Given this list of marker genes NBR2, DPY30, NOL6, NSUN6, FAF1, CHEK1, TAF13, EED, ITFG1, ESYT1, KIFBP, FAM174B, MTND5P11, EMC8, CHERP, RBM33-DT, CZIB-DT, IPO8, EIF3D, PAF1, ZEB1, ZNHIT6, CEPT1, UBR1, SUPT5H, CNIH2, NBR1, GOLGA7, RAP2A, GGCX, FAM230G (family with sequence similarity 230 member G), CWF19L2, FKTN-AS1, FKBP15, MYO9A (NCBI Gene Id 80251), ASB7, KLRC2, CRLS1, EIF3K, HS2ST1, NAALADL2, MZF1, CIAO3, MBD4, ELP3, SNORD13, SELENOF, COA8, MRPS12, RPS16, FBRS, CTNNBL1, SOX2-OT, C4orf46, CEP290, PDPR, NUDT9, MT-TL1, PBRM1, NCOA5, PHAF1, SENP8, ARL5B, LSM4, GNL3, SARS2, ETFDH, RNF139, CDK8, PCNX4-DT, E4F1, LEO1, MT-TP (NCBI Gene Id 4571), FAAP100, TGDS, UTP25, ETFRF1, DNAJC9-AS1, TRAPPC5, RNF111, PHKB, DNAJC19, KLHDC9, EPRS1, PDPR2P, EIF4B, NDFIP2, C4orf36, HM13, DGCR6L, FKTN, PSMB6, EPC2, RALGAPA1, FAM229B, NDUFS5, DPH5-DT, UTP14A, TMTC3, MT-TE, TUBE1, MT-TF, EEF1G, AFF1, USP48, TMEM177, MKS1, MTCO3P12, VAMP8, PDSS2, TCEA1, TBC1D23, TBC1D8, CEP192, DDI2, MCM8-AS1, TIMM23, MED29, SLC31A1, MT-TT, ZZEF1, MRFAP1L2, TXNL1, MECOM, ZNF862, DLAT, HAX1, TOMM7, PARG, CLEC16A, KIAA2013, MT-RNR1, TAFAZZIN (NCBI Gene Id 6901), MT-ND1, DPH5, ZC3H15, CEP192-DT, MRFAP1L1, ANAPC7, CENPBD2P, BAG5, WDR7, NAA30, MRPS16, LRRCC1, CCDC184, ZC3H10, PARGP1, TTC23, RPS6KL1, LINS1, MPC1, TIMM23B, PIGK, CYB5D2, NEURL4, NDUFAB1, RIOK2, PCNX4, SFR1, MT-ND6, ZEB1-AS1, LINC02482, RAD52, IFT122, MPC1-DT, NDFIP2-AS1, PSMD8, NSUN5, MEF2C, COX4I1, PKN2, MCTS1, MRFAP1, RNF139-DT, CNOT11 (NCBI Gene Id 55571), SUGT1P1, CCDC174, BRCA1, MRPL15, TTI2, TSEN2, DNAI7, DRAM2, MAP4K1, RBM33, CZIB, DCAF8, CDKN2C, ABT1, MCTS2, AASDH, RIC8A, BET1L (NCBI Gene Id 93155), ZNF330, PPP5C, TAF5, CACUL1, ZMAT2 (zinc finger matrin-type 2), here is a description of the gene set: Human Gene Set: SETBP1_TARGET_GENES from publication Yevshin I, Sharipov R, Kolmykov S, Kondrakhin Y, Kolpakov F (PMID 30445619) studied in species Homo sapiens Genes containing one or more binding sites for (SETBP1) in their promoter regions (TSS -1000,+100 bp) as identified by GTRD version 20.06 ChIP-seq harmonization.